The following is a description of a gene set: studied in species Homo sapiens Binding to a BH3 protein domain, present in Bcl-2 family members. The BH3 domain is a potent death domain and has an important role in protein-protein interactions and in cell death. Human Gene Set: GOMF_BH3_DOMAIN_BINDING, and this is the list of marker genes: BCL2, MCL1, IRGM, BCL2L1, RACK1 (NCBI Gene Id 90938), BAX